The following is a description of a gene set: species: Homo sapiens Human Gene Set: GOBP_MESODERMAL_CELL_MIGRATION The orderly movement of mesodermal cells from one site to another., and this is the list of marker genes: APELA, MESP1, NCKAP1, EPB41L5, LRP5, FGF8